Given this list of marker genes ENTPD1, AHNAK, UGCG, FCRL2, LINC00926, SNX9, FCRL5, ITGB7, NEDD9, PLPP5, TBC1D9, TMC8, DENND1C, PLEK, FCRL3, SH3BP1, SH2B2, PKIG, CD5, NFKBIE, MS4A6A, LPAR5, EEIG1, CFLAR (CASP8 and FADD like apoptosis regulator), TENT5C, LY9, CCR7, CLEC17A, VSIR, RAB8B, RGS10, ZNF827 (NCBI Gene Id 152485), MCOLN2 (mucolipin TRP cation channel 2), CD1C, DNPH1, TNFRSF13B, CLECL1P, TLR10, CD1D, ARHGAP9, RASA4, CD27 (CD27 molecule), NFKBIZ, IL10RA, CDC42EP3, FCER2, DUSP2, ACP5, TMEM154, PELI1, SNX11, KCNN4, CTSZ, SELL, RBKS, IL27RA, PPP1R16B, PLK3, RHOF, EGR1, BCL2A1, CD82, METTL8, SIGLEC10, ADAM8, TRBC2, MIR155HG, FCGBP, S100A4, HCST, CREM, PCED1B, CMTM3, APOBEC3C, IGFLR1, CHMP7, TNFRSF13C (TNF receptor superfamily member 13C), LTA, SRGN, PTPN22, U2AF1L4, RRAS2, NR4A2, MPEG1, S100A10, BCL2, DOK2, ZBP1, CD40, CR2, MYO1E, SCML4, NAPSA, RAB11FIP1, EVI2A, HLA-DOB (NCBI Gene Id 3112), SEL1L3, RUNX3, APOBEC3G, CD44, BIN2, ITGAL, CYBB, PRKCD, GM2A, CEPT1, IRF5, DUS2, ARHGAP24 (NCBI Gene Id 83478), RHOC, LINC01480, LRRK2, ARL4C, CCR6, C1orf162, IFNGR1, SPOCK2, ADAMTS6, KLF4, SKAP1, TRAC, PTGER4, RGCC, ZNF490, CTSH, PARVB, RHEX, NR4A3, SHISAL2A, KBTBD8, RASA4B, SNX10, SEMA4A, CXCR5, TRAF5, TFEB, ADAM28, MARCHF1, WNT10A, SEMA7A, GPR183, S100A6, TTN, CCND2, SP140, BIRC3, CHI3L2, TYMP, EVI2B (NCBI Gene Id 2124), PDE7A, SH3YL1, GRK3, ZDHHC21, RAB29, RGS1, PNOC, COL19A1, LPXN, ZNF331, ABI3, here is a description of the gene set: from publication He P, Lim K, Sun D, Pett JP, Jeng Q, Polanski K, Dong Z, Bolt L, Richardson L, Mamanova L, Dabrowska M, Wilbrey-Clark A, Madissoon E, Tuong ZK, Dann E, Suo C, Goh I, Yoshida M, Nikolić MZ, Janes SM, He X, Barker RA, Teichmann SA, Marioni JC, Meyer KB, Rawlins EL (PMID 36493756) species: Homo sapiens Human Gene Set: HE_LIM_SUN_FETAL_LUNG_C5_CD5_POS_CCL22_NEG_MATURE_B_CELL CD5+ CCL22- mature B